Given this list of marker genes Raet1d, H2-T22, Clec2h, Clec2e, H2-M2, Clec2d, H2-D1, Ptpn6, H2-M10.4, H60c, H2-M10.6, H2-Q7, Mill1, H2-Q2, H60b, Raet1e (NCBI Gene Id 379043), H2-M10.1, Ulbp1, H2-M9, H2-Q10, H2-Q4, H2-M10.3, Ulbp3, H2-M1 (histocompatibility 2, M region locus 1), H2-M11 (histocompatibility 2, M region locus 11), H2-K1, H2-T23, Clec2f, Clec2g, Clec2i, Mill2, H2-Q1, H2-T3, H2-M10.2, H2-Q6, H2-M5, H2-T10, H2-M10.5, here is a description of the gene set: Binding to a lectin-like natural killer cell receptor. studied in species Mus musculus Mouse Gene Set: GOMF_NATURAL_KILLER_CELL_LECTIN_LIKE_RECEPTOR_BINDING